The following is a description of a gene set: species: Homo sapiens Human Gene Set: PIEPOLI_LGI1_TARGETS_UP Up-regulated genes in U87 cells (glioblastoma multiforme, GBM) engineered to stably express LGI1. from publication Piepoli T, Jakupoglu C, Gu W, Lualdi E, Suarez-Merino B, Poliani PL, Cattaneo MG, Ortino B, Goplen D, Wang J, Mola R, Inverardi F, Frassoni C, Bjerkvig R, Steinlein O, Vicentini LM, Brüstle O, Finocchiaro G (PMID 16533756) Disruptions of LGI1 in glioblastoma (GBM) cell lines and LGI1 mutations in families with autosomal dominant epilepsy imply a role for LGI1 in glial cells as well as in neurons. Although we and others could not find LGI1 mutations in malignant gliomas, our initial studies appeared to support the idea that LGI1 is poorly expressed or absent in these tumors. Microarray data suggested that LGI1 could be involved in the control of matrix metalloproteinases, and we found that tumors derived from U87 glioblastoma cells overexpressing LGI1 were less aggressive than U87 control tumors. To our surprise, we observed that LGI1 expression after differentiation of murine neural stem cells was robust in neurons but negligible in glial cells, in agreement with immunohistochemistry studies on rodent brain. This observation could suggest that the variable levels of LGI1 expression in gliomas reflect the presence of neurons entrapped within the tumor. To test this hypothesis, we investigated LGI1 expression in parallel with expression of the neuronal marker NEF3 by real-time PCR on 30 malignant gliomas. Results showed a strong, positive correlation between the expression levels of these two genes (P < 0.0001). Thus, our data confirm that LGI1 is involved in cell-matrix interactions but suggest that its expression is not relevant in glial cells, implying that its role as a tumor suppressor in gliomas should be reconsidered., and this is the list of marker genes: TIMP3, DIRAS3, HLF, RYR2, FGF13, FGL2, MAF, GAGE1, CST7, MAGEA5P, MAGEA3, CTNNA2, HMGB3 (NCBI Gene Id 3149), EPHA5, BCL2L11, NNT, TNFRSF11B